Given this list of marker genes BMP4, NFIB, LMNA, ISL1, WNT5A, WNT11, CTNNBIP1, PHF14, here is a description of the gene set: species: Homo sapiens Human Gene Set: GOBP_NEGATIVE_REGULATION_OF_MESENCHYMAL_CELL_PROLIFERATION Any process that decreases the frequency, rate or extent of mesenchymal cell proliferation. A mesenchymal cell is a cell that normally gives rise to other cells that are organized as three-dimensional masses, rather than sheets.